Given this list of marker genes MMP28, MSTN, CSF1R, CYP19A1, CXCL17, C5, IL34, MAPK3, CCL5, DDT, C5AR1, CMKLR1, SLAMF8, RARRES2, TRPV4, CSF1, MIF, PTK2, CCL2, C3AR1, THBS1, TNFSF18, STAP1, PTPRJ, MDK, SLAMF1, MTUS1, MAPK1, AKIRIN1, PTK2B, here is a description of the gene set: Human Gene Set: GOBP_REGULATION_OF_MACROPHAGE_CHEMOTAXIS Any process that modulates the rate, frequency or extent of macrophage chemotaxis. Macrophage chemotaxis is the movement of a macrophage in response to an external stimulus. species: Homo sapiens